The following is a description of a gene set: Genes up-regulated in peripheral blood mononuclear cell non-responders vs responders in adults (<50) after exposure to Heptatitis B surface antigen vaccine (HBsAg), time point 35D Individuals fail to elicit protective antibody after hepatitis B vaccination remain at risk for hepatitis B virus infection. Analysis of the transcriptome of peripheral blood mononuclear cells (PBMCs) is essential to elucidate the characteristics of gene expression in non-responders. In this study, we enrolled seven responders who had received three injections and seven non-responders who had six injections of hepatitis B vaccine before. All the participants were then vaccinated with a three-dose boost regimen. Microarray analysis and Luminex assay were applied to examine mRNA expression and Th1/Th2/Th9/Th17/Th22/Treg cytokine and chemokine profiles in non-responders and responders. Differentially expressed genes in PBMCs of non-responders at 5 time points, i.e. pre-vaccination, 3<sup>rd</sup>, 7<sup>th</sup>, 28<sup>th</sup> day post the first dose vaccination and 7<sup>th</sup> day post the second dose vaccination indicated a dense network trend. Compared with responders, nine coding genes (BPI, DEFA1B, DEFA4, CEACAM8, MMP8, FOLR3, LTF, TCN1 and TKTL1) were significantly up-regulated in non-responders at all 5 time points, which could probably be the characteristic genes in hepatitis B vaccine non-responsiveness. Gene ontology analysis revealed that most of the DEGs were related with immune responses. Validation results of these genes using quantitative real-time polymerase chain reaction were mostly consistent with the results of microarray. Cytokine analysis demonstrated that IL-27 and CXCL12 concentrations in responders were significantly higher than non-responders on the 3<sup>rd</sup> day after the first dose and 7<sup>th</sup> day after the second dose of vaccination, respectively. No significant difference was observed in other cytokine and chemokine signatures between the two groups. In conclusion, our results revealed characteristic transcriptome and cytokine changes in hepatitis B vaccine non-responders after boost immunization. from publication Qiu S, He P, Fang X, Tong H, Lv J, Liu J, Zhang L, Zhai X, Wang L, Hu Z, Yu Y (PMID 29580160) studied in species Homo sapiens Human Gene Set: QIU_PBMC_HEPTATITIS_B_SURFACE_ANTIGEN_AGE_UNDER50_NON_RESPONDERS_VS_RESPONDERS_35DY_UP, and this is the list of marker genes: MMP8, DLX4, SERPING1, CEACAM8, CXCL10 (C-X-C motif chemokine ligand 10), CRISP3, IFNG, FCGR1BP, FCGR1A, DEFA4, LTF, CCL4, TCN1, TKTL1, DEFA1B